Given this list of marker genes ADCYAP1, SLC4A8, POU4F1, IGSF9B, SEMA4D, SULT4A1, NPPA, MLANA, MC2R, ADAMTSL2, NUDT13 (nudix hydrolase 13), PSG1, GPR19, CD40, WNT10B, SLC12A4, POU6F2, BCL3, KRT33A, SLC6A9, PRSS16, TMSB4Y, CNTN6 (NCBI Gene Id 27255), TNFRSF25, NCKIPSD, IGHMBP2, TNP1, KRT86, PCBP3 (NCBI Gene Id 54039), RREB1, here is a description of the gene set: Human Gene Set: CAR_TNFRSF25 Neighborhood of TNFRSF25 tumor necrosis factor receptor superfamily, member 25 in the CAR expression compendium studied in species Homo sapiens Neighborhood of TNFRSF25